The following is a description of a gene set: studied in species Homo sapiens from publication Blanco-Melo D, Nilsson-Payant BE, Liu WC, Uhl S, Hoagland D, Møller R, Jordan TX, Oishi K, Panis M, Sachs D, Wang TT, Schwartz RE, Lim JK, Albrecht RA, tenOever BR (PMID 32416070) Analysis of the transcriptional response to SARS-CoV-2 compared with other respiratory viruses, including MERS-CoV, SARS-CoV-1 (SARS), human parainfluenza virus 3 (HPIV3), respiratory syncytial virus (RSV), and IAV. Genes up-regulated in SARS-CoV-2 infection (Calu-3 cells, MOI: 2, 24hpi) Human Gene Set: BLANCO_MELO_COVID19_SARS_COV_2_INFECTION_CALU3_CELLS_UP, and this is the list of marker genes: NT5C3A, TENT5A, ZNF267, THBS1, SAMD9L, SYT1, PDCD1LG2, NOD2, SP8, KRTAP2-3, PHLDB2, ZEB2 (zinc finger E-box binding homeobox 2), MT2A, FUT1, CLEC4E, DHX58, C11orf96, CMPK2, BAHCC1, PTGER4, DUSP1, TNFRSF11B, NCOA7, FOSB, IL12A (interleukin 12A), PTGER2, STC2, HERC5, BDKRB2, SPRY2, PPP1R15A, ATF3, TNFAIP3, BACH2, ACKR4, KLF6, SAMD9, PARP12, DNAH17, ZFP36, SP100, CSF2, KCNV1, LAMA2, MAP3K8, PARP10, NEDD4, ISG15, GBP1, GBP4, CCL2, IRS2 (NCBI Gene Id 90066), DUOXA2, PLAT, STAT1, IFI44, CCL5, CCL20, OASL, USP30-AS1, RIGI, NR4A3, APOL6, CYP1A1, SERPINB7, SEMA3A, PDZD2, NLRP1, APOBEC3G, BEST1, IL15RA, NLRP3, BST2, IFI35, SLFN5, IDO1, EGR2, THEMIS2, CH25H (cholesterol 25-hydroxylase), GBP5, IKZF3, IRAK2, CREB5, LMO2, IFNL1, ITGAM, RBM43, TNFSF10, ICAM1, PARP14, RND1, SP110, DEPP1, SYNPO2, DTX3L, CD274, RAET1L, PER1, LRRN3, GBP1P1, UBASH3A, BCL2L14, ZBTB10, HAND1, PDE4B, SCN3A, INHBE (NCBI Gene Id 83729), HDX, MIR155HG, NUPR1, IRF7, CD69, INHBA (NCBI Gene Id 3624), PPM1K, CYP1B1, UBE2L6, LTB, BCAT1 (branched chain amino acid transaminase 1), LIFR, TNFRSF9, IL6, CAVIN2, ALDH1L2, DUOX2, NAV2, NKX3-1, PSMB8-AS1, CX3CL1, IFITM2, APOL3, RTP4, ASNS, HLA-J, KDM7A, CXCL10 (NCBI Gene Id 3627), IGF2-AS, IFNL2, FGF19, IFNB1, ZBTB20, GIMAP2, TNFSF14, KMO, IFIT1, CARINH, HBEGF (heparin binding EGF like growth factor), STAT2, EGR1, DUSP8, CCN2, IFIH1, LAMP3, SERPINB9 (NCBI Gene Id 5272), SERPINE1, TMEM140, TCIM, HLA-V, PKP1, ZC3H12C, IL1B, CXCL3, CXCL11, IL10RA, LINC01907, SLC15A3, RNF213, ETV7, LEISA1, UBQLNL, EIF2AK2, USP18, HSD17B14, IFIT5, G0S2, OTUD1, FSD1L, EPSTI1, DAPP1, CXCL8, TRPC4, KLHDC7B, PTAFR, PA2G4P4 (proliferation-associated 2G4 pseudogene 4), IFNL4, PTGS2, LHB, NOCT, HDAC9, SELE, NAPSB, TAGAP, IFI16, MMP13, LST1, SDS, BCL2A1, IFIT2, TXNIP, PHF11, KIF21B, ISG20, C1QTNF1, TNFRSF10B-AS1, STX11, TRIM5, CSF3, TRANK1, PRDM1, KLF10, FYB2, NR1I2, PCK2, NR1D1, PCK1, TRIM22, MX1, XRN1, OAS2, MARCHF4, EGOT, H1-3, SAMHD1, BMP2, RASGEF1B, NAV3, IFNL3, SEMA7A, PLA1A, ANKRD1, ZC3HAV1, PML, AKAP12, FFAR2, XKR9, HELZ2, CASP1, RTL9, ACTN2, ULBP1, NUAK2, KLF9, HIVEP2, BBC3, CXCL2, DDO, RBM11, NEURL3, TIPARP, PARP9, MUC4, SLC16A6, LRP2, RSAD2, ADRB2, CCL22, TRAF1, ANKRD33B, CYTH4, TAP1, CHAC1, XAF1, WFDC5, DDX60, PGLYRP2, NDUFA4L2, ZNF442, OAS1, CXCL9, TDRD7, RUNX2, AMOTL2 (angiomotin like 2), SERPINB2, PLAAT2, RASGRP1, IRF1, APOL4, LGALS9, BIRC3, ROCK1P1, CSRNP1, TNF, FUT3, JUN, IFI44L, C6orf58, VCAM1, ARRDC3, DEPDC7, HSH2D, TNFSF13B, ECE1-AS1, FLT3LG, NPR1, CNTN4, FAP, NLRC5, NFKBIA, DUOX1, SLC5A5, MAST4, TRIM21, IL23A, GADD45A, PLEKHG7, OAS3, BATF2, IFITM1, ZBP1, HMGN2P46 (NCBI Gene Id 283651), MX2, KIF6, COL4A1, IL1A, PLA2G4C, MB21D2, ADAMTS6, NEAT1, C1R (NCBI Gene Id 791254), CSF1, IFIT3, CTH, TNFAIP2, PPP4R4, TLR6 (toll like receptor 6), RASGRP3, KIT, ZNFX1, DDX60L, PMAIP1, TLR3, NGFR, PNPT1, SAA4, ARRDC4, EDN2, GBX2, PTX3, SERPINA10, KLF4